The following is a description of a gene set: Catalysis of the joining of two molecules via a carbon-oxygen bond, with the concomitant hydrolysis of the diphosphate bond in ATP or a similar triphosphate. Mouse Gene Set: GOMF_LIGASE_ACTIVITY_FORMING_CARBON_OXYGEN_BONDS species: Mus musculus, and this is the list of marker genes: Lars2, Aars1, Dalrd3, Hars1, Hars2, Wars1, Eprs1, Cars2, Mars1, Rars2, Tars2, Sars1, Kars1 (NCBI Gene Id 85305), Iars2, Lars1, Nars2, Vars2, Aarsd1, Sars2, Vars1, Dars2, Rars1, Aars2, Farsa, Qars1 (glutaminyl-tRNA synthetase 1), Ears2, Fars2, Iars1, Yars2, Wars2, Pars2, Lrrc47, Farsb, Cars1, Gars1 (NCBI Gene Id 353172), Tars1, Yars1, Nars1, Mars2, Tars3, Dars1